Given this list of marker genes Pink1, Pappa, Isca1, Pfkl, Vezf1, Tle5, Vegfb, Jund, Snrpc, Fxr2, Zfp775, Rbpms, Pdlim4 (NCBI Gene Id 54412), Dynll2, 4930429F24Rik, H2-Ab1, Homer1, Rab3a, Igsf23, Gm14295, Ube2l6 (ubiquitin-conjugating enzyme E2L 6), Med25, Ccnd1, Ppme1, Map2k5, Id3, Cpeb3, Ddx18, Kdm2a, Arpc1b, Hnrnpd, Lmtk2, Retnlg, Macrod1, Hspb7, Zfp579 (zinc finger protein 579), Matr3, Zmym2, Tmsb10, Prxl2a, Scn10a, Prpf19 (NCBI Gene Id 28000), Szt2, Inpp4a (NCBI Gene Id 96938), Ly6a, Aldob, Paqr9, Agpat3, Selplg, C1qb, Ctnnbip1, Hdac4, Mdga1, Capg, Cfl1, Car2, H2-Eb1, Ccnd2, Fxyd5, Aldh1l2, Cux1, Efhd2, Golga7b, Hba-a1, Sp2, Cops5, Bpgm, Rnf216, Mkrn1, Slc25a39, Wbp11, Oaz1, Mief2, Arhgdib, Abca12, Ipo7, Samd8, Cdkn1b, Cxcl1, Rbfox2, Serpina3k, Tagln2, Max, Arpc3, Aph1a, Kcnd2, Esrra, Pxmp2, Fbxo9, Spr, Gfpt1, Agpat1, Gca, Nol3, Ambp, Coro1a, Zfp704 (NCBI Gene Id 269407), Ube2r2, Slc25a47, Rragd, Ppp1r1b, Fech, Cactin, Lamb3, Nr2f2, Nifk, Nkx2-5, Rac2, Olfm1, Dtna, Tdrkh, Hycc2, Gc, H2-Q10, Syt7, Ptms, Gnmt, Ctss, Dmpk, Mtr, Pnpo, Slc38a4, Gatd3a, Ewsr1, Cd74, Fam220a, Rnf10, Vamp2, Bri3, Amacr, H2-Aa, Ppm1g, Fbxo40, Ube2m, Tspan9, here is a description of the gene set: from publication Tabula Muris Consortium (PMID 32669714) Mouse Gene Set: TABULA_MURIS_SENIS_HEART_ATRIAL_MYOCYTE_AGEING species: Mus musculus